Given this list of marker genes SUCLG2, FMO1, CBS, NUDT8, DPEP2, HEXB, GNS, MTRR, CHAC2, NUDT19, SGSH, HYAL4, GUSB, ACAT1 (NCBI Gene Id 38), SUCLA2, ENSG00000274276, MLYCD, CDO1 (NCBI Gene Id 105379131), SUCLG1, GGT2P, IDUA, GGTLC3, HPSE, HGSNAT, ACOT7, HYAL1, GGTLC2, MPST, MAT1A, AGXT, FITM2, GGT3P, CHAC1, GLB1, NUDT7, DPEP1, NAGLU, TST, GGT5, ABCD1, GGT7 (NCBI Gene Id 2686), GPC1, VNN1, GGT1, IDS, CSAD, BLMH, GGTLC1, here is a description of the gene set: studied in species Homo sapiens Human Gene Set: GOBP_SULFUR_COMPOUND_CATABOLIC_PROCESS The chemical reactions and pathways resulting in the breakdown of compounds that contain sulfur, such as the amino acids methionine and cysteine or the tripeptide glutathione.